Given this list of marker genes MEIS2, DUSP10, CREB1, DSCAM, SOX2, AMD1, NRXN2, ZNF385A, CEP83, here is a description of the gene set: species: Homo sapiens Genes having at least one occurence of the motif CGCAAAA in their 3' untranslated region. The motif represents putative target (that is, seed match) of human mature miRNA hsa-miR-450 (v7.1 miRBase). Human Gene Set: CGCAAAA_MIR450